Given this list of marker genes ATF2 (NCBI Gene Id 1386), SIX3, SPI1, XKR6, JAG2, SLIT2, XKR4 (NCBI Gene Id 114786), PAX2, LEF1, FZD5, MIR19B1, LRP5, CRYAA, CRYAB, KIF1B, PML, NKX2-5, NOTCH1 (notch receptor 1), BMP4, CDKN2A, CHEK1, FOXC1, HNF1B, BCL2L11, XKR7, XKR8, BMP7, ZPR1, ROBO2, TGFB2, HAND2, FGF4, SLIT3, FOXC2, VDR, TNFRSF1A, MEGF10, CCN1, BAX, TNFRSF1B, PAX8 (paired box 8), SCRIB, BAK1, PPP2R1B, here is a description of the gene set: Human Gene Set: GOBP_APOPTOTIC_PROCESS_INVOLVED_IN_DEVELOPMENT studied in species Homo sapiens Any apoptotic process that is involved in anatomical structure development.